Given this list of marker genes Usp1, Bap1, Usp10, Atxn3, Usp15 (NCBI Gene Id 70921), Usp16, Usp9x, Usp7, Usp47, here is a description of the gene set: Mouse Gene Set: GOBP_MONOUBIQUITINATED_PROTEIN_DEUBIQUITINATION The removal of the ubiquitin group from a monoubiquitinated protein. studied in species Mus musculus